Given this list of marker genes H3f4, Rbbp4, Nasp, Chaf1b, Chaf1a, Asf1a, Asf1b, here is a description of the gene set: studied in species Mus musculus The formation of nucleosomes on newly synthesized DNA, coupled to strand elongation. Mouse Gene Set: GOBP_DNA_REPLICATION_DEPENDENT_CHROMATIN_ASSEMBLY